Given this list of marker genes Agl, Pgam1, Snx4, Cyfip2, Arhgap32, Slc22a5, Gpc5, Dcun1d4, Specc1, Ptpdc1, Cacnb4, Gucy1a2, Cd2ap, Oscp1, Rab13, Gm15080, Cops3 (NCBI Gene Id 26890), Scyl3, Sh3kbp1, Pex7, Mid1, Clstn1, Nqo2, Gorab, Stk38, Neurod1, Mef2a, Txlng, Id2, Tnfrsf11b, Btaf1, Cttnbp2nl, Gria4, Gm15093 (NCBI Gene Id 100039890), Hnrnpa3, Fut9, Dock4, Fbxo30, Mtor, Tmem132b, Clock, Srxn1, Zfp616, Fam120b, Tmtc1 (transmembrane and tetratricopeptide repeat containing 1), Reg1, Ppargc1a, Prune2, Hyal6, Gm15085, Gm15097, Nufip2, Ipo11, Cbfb, Zfp39, Tk2 (NCBI Gene Id 57813), B230219D22Rik, Capza2, Trim59, Gja8, Pdik1l, Klhl38, Cmpk1, Parg (NCBI Gene Id 26430), Syndig1, Muc15, Ppp2ca, Itch, Cdx4, Nlrp1a, Plxdc2, Adipor1, Taok1, Smg1 (NCBI Gene Id 72492), Cyp1b1, Katnbl1, Asb7, Lpcat2, Odf2l, Ncoa2, Bet1, Cd47 (CD47 antigen (Rh-related antigen, integrin-associated signal transducer)), Map3k20, U2surp, Tsc22d2, Ccn4, Zfp235, Nudt4, Clxn, Cavin2, Spata31d1c, Slc7a14, Usp29, Apol10a, Dennd6a, Hectd2, Tmed1, Zfp24, Pdxdc1 (NCBI Gene Id 94184), Nfat5, Brip1 (NCBI Gene Id 73108), Fbxl17, Cpeb2, Stag2, Gm15127, Aqp4, Crebrf, Tmod1, Dpp4, Tns4 (NCBI Gene Id 217169), Serinc1, Olfm3, Zbtb2, Spic, Bdnf, Slc25a51 (solute carrier family 25, member 51), Gm15091, Gtf2a1, Nos1, Scml4, Itga11, Erbb4, Slc5a12, Zfp202, Klhdc8a (kelch domain containing 8A), Kif21b, Plxna2, Mmgt1, Flg2, Zfp36l1, Gm94, Slitrk6, Sri, Setx, Zfp654, Arid4b, Nsun6, Plaat1, Syap1, Ric8a, Scfd1 (Sec1 family domain containing 1), Car12, Pank3, Fgf7, Pigr, Pde5a, Akain1, Gfpt1 (NCBI Gene Id 72178), Wdfy2, Klhl24, Pxk, Fnip1, Kpna4, Cadm2, Pus10, Camk2n1, Apol11b, Marchf5, Dnal1, Tspan12, Atad1, Tada2b, Tubb2a, Fam120c, Mtf1, Zbtb6, Arhgap42, Luzp4, Xrn1, Api5, Zfp780b, Bhlhe22, Naaladl2, Tor1aip2, Phf20l1, Them7, A630073D07Rik, Bcl2l11, Gmfb, Ott, Man2a1 (NCBI Gene Id 17158), Gm15114, Scai, Il6, Mtfr1, Sntb2, Rnf38, Zswim5, Tnfaip8, Slc30a4, Zfp820, Vps35, Glcci1, here is a description of the gene set: from publication Chen Y, Wang X (PMID 31504780) Mouse Gene Set: MIR_7006_3P studied in species Mus musculus Genes predicted to be targets of miRBase v22 microRNA mmu_miR_7006_3p in miRDB v6.0 with MirTarget v4 prediction scores > 80 (high confidence targets).